The following is a description of a gene set: During acute viral infections, naïve CD8+ T cells differentiate into effector CD8+ T cells and, after viral control, into memory CD8+ T cells. Memory CD8+ T cells are highly functional, proliferate rapidly upon reinfection and persist long-term without antigen. In contrast, during chronic infections, CD8+ T cells become “exhausted” and have poor effector function, express multiple inhibitory receptors, possess low proliferative capacity, and cannot persist without antigen. To compare the development of functional memory T cells with poorly functional exhausted T cells, we generated longitudinal transcriptional profiles for each. Genes up-regulated in CD8 T cells: naïve versus effectors at day 15. Human Gene Set: GSE41867_NAIVE_VS_DAY15_LCMV_EFFECTOR_CD8_TCELL_UP species: Homo sapiens from publication Doering TA, Crawford A, Angelosanto JM, Paley MA, Ziegler CG, Wherry EJ (PMID 23159438), and this is the list of marker genes: RSL24D1, SPCS1, HTT, TMEM19, ZNF217, INTS3, CMC2, MED30, ANAPC15, RGS12, TOR1B, CSE1L (chromosome segregation 1 like), ANAPC7, MAP2K2, NUP133, TMEM263, DTX3L, HSPA13, PRKCA, PTGES2, SEC23A, NFIL3, POLR2K, UNG, FAM174C, DBT, DPP3, TWNK, UBXN2B, ABCF1, AACS, YWHAQ (tyrosine 3-monooxygenase/tryptophan 5-monooxygenase activation protein theta), NCBP1, NIP7, COX17, ALG5, FOCAD, CYB5R1, TSEN2, HIBCH, HDAC6, PEX19, WASHC5, ANAPC11, OST4, UQCRC2, PPP1R7, CSNK2A2, NDUFB3, IQCG, MORN2, MTG1, HAUS1, RFC1, CCT5, WDR3, ADH5, EIF3D (NCBI Gene Id 8664), POR, ACTR6, ANAPC5, STARD4, KLHDC2, YBX1, SASS6, SLFN5 (NCBI Gene Id 162394), POLD3, CLNS1A, SPIDR, AATF, ACTR3B, CCDC34, SNUPN, RAB35, POLR1D, ZPR1, PCCA, CLTB, WDR76, RNASEH2C, KPNA6, PIGG, TMEM39B, SMU1, IFIT1, CENPM, DMAC1, DDX47 (DEAD-box helicase 47), AKR1A1, GALE, XKR8, AFP, CTNNBIP1 (catenin beta interacting protein 1), DDX52 (DExD-box helicase 52), THAP2, LSM7, MSH2, CUL5, SRA1, AGK, VCP, PCCB, MED22, GCLM, NUDT7, FABP5, SCOC, LRPPRC, NSMCE1, RAB29, HDAC3, ZNF213, CWF19L1, CMSS1, PSME4, OVCA2, IFITM3, BMS1, GNG12, ARHGDIG, TMEM256, MRPS24, EFL1, ERP44, PCBD2, PGD, MBD3, RAP1A, SET, UTP25, PSMC3, XRCC5 (NCBI Gene Id 7520), SDHC, TNFAIP8L1, PMS2, THOC7, ILF2, VIPAS39, DOLK, TBL3, FASTKD2, CETN3, SNIP1, PIN4, RECQL4, DCPS, SLAMF7, APOA2, SEC14L4, INTS4 (NCBI Gene Id 92105), COPS2, COX18, NUP188, ESAM, SANBR (SANT and BTB domain regulator of CSR), PRKCSH, PARP11, SIKE1, WDR73, VIRMA (NCBI Gene Id 25962), NANS, TRIM14, PEX10, RAVER1, BAG2, MED8, MTLN, GOLGA7 (golgin A7), NKX2-6, PREP, DANCR, MCMBP, CACNA1A, LSM6, C2orf49, SUCLA2, TMX1, HSD17B7, DCAKD, CDC123, GBP4, SDR39U1, DET1, EIF3B, HNRNPA1 (NCBI Gene Id 780920), RAE1, ACTA1, PABPN1, IFT56, PCYT2, IFT25, UFSP1, ARV1, MID1IP1, OGFR, FAF1, EXOSC5, DPAGT1, NPAT, ELAC2 (NCBI Gene Id 60528)